Given this list of marker genes Scn10a, Adora1, Rho, Grik2, Ano1, Mmp24, Tlr4, Nrg1, Opn4, Tac1, Ngfr, Asic3, Scn9a, Ntsr1 (neurotensin receptor 1), Ephb1, Ano3, Cxcl12, Wdr47, Nr2f6, Disc1, Comt, Pawr, Htr2a, Prdm12, Lxn, Scrn3, Arrb2, Trpv1, Ntrk1, Scn11a, Drgx, Cxcr4, Calca (calcitonin/calcitonin-related polypeptide, alpha), Tac4, here is a description of the gene set: The series of events in which a temperature stimulus (hot or cold) is received and converted into a molecular signal. Mouse Gene Set: GOBP_DETECTION_OF_TEMPERATURE_STIMULUS species: Mus musculus